Given this list of marker genes Tmem59, Sh2d1b1, Myl6, Ski, Ypel1, Cotl1, Gng5, Rgs10, Srgn, Ncf4, Pmepa1, Dennd1b, Sec11a, Itgb7, Car2, Tmod3, here is a description of the gene set: Genes positively differentially expressed in cell type: NK cell upon treatment with cytokine: TGF-β1 in mouse lymph nodes in vivo. Mouse Gene Set: CUI_NK_CELL_TGF_BETA_1_RESPONSE_UP Cytokines mediate cell-cell communication in the immune system and represent important therapeutic targets. A myriad of studies have highlighted their central role in immune function, yet we lack a global view of the cellular responses of each immune cell type to each cytokine. To address this gap, the authors created the Immune Dictionary, a compendium of single-cell transcriptomic profiles of more than 17 immune cell types in response to each of 86 cytokines (>1,400 cytokine-cell type combinations) in mouse lymph nodes in vivo. A cytokine-centric view of the dictionary revealed that most cytokines induce highly cell-type-specific responses. For example, the inflammatory cytokine interleukin-1β induces distinct gene programmes in almost every cell type. A cell-type-centric view of the dictionary identified more than 66 cytokine-driven cellular polarization states across immune cell types, including previously uncharacterized states such as an interleukin-18-induced polyfunctional natural killer cell state. species: Mus musculus from publication Cui A, Huang T, Li S, Ma A, Pérez JL, Sander C, Keskin DB, Wu CJ, Fraenkel E, Hacohen N (PMID 38057668)